Given this list of marker genes ACY1, here is a description of the gene set: Aminoacylase 1 (ACY1) is a cytosolic, homodimeric zinc-binding metalloenzyme with a wide range of tissue expression. It hydrolyses acylated L-amino acids (except L-aspartate) into L-amino acids and an acyl group. It can also hydrolyse N-acetylcysteine-S-conjugates. Defects in ACY1 can cause aminoacylase-1 deficiency (ACY1D; MIM:609924) resulting in encephalopathy, delay in psychomotor development, seizures and increased urinary excretion of several N-acetylated amino acids. part of: Metabolic disorders of biological oxidation enzymes studied in species Homo sapiens Reactome Pathway: Defective ACY1 causes encephalopathy